The following is a description of a gene set: Human Gene Set: HP_LONG_NOSE Distance from nasion to subnasale more than two standard deviations above the mean, or alternatively, an apparently increased length from the nasal root to the nasal base. Long nose species: Homo sapiens, and this is the list of marker genes: RNU4ATAC, SOX18, POLE, PIEZO2, TRPM3, ZFX, SRCAP, NOTCH2, RECQL4, TAF4, SCUBE3, SETD2, PIGS, KAT6B, SOX11, GABRA3, SMG9, NOG, AP4E1, OPHN1, JAG1, FRA10AC1, ACTG1, ZBTB18, XRCC4, AFG2A, NEXMIF, SLC9A6, EXTL3, NBN, MED12, ACTB, ABL1, PIGU, GJA1, THOC6, ZMYM2, ASXL3, SATB2, AP1S2, TWIST1, FGFR2